The following is a description of a gene set: Mouse Gene Set: LE_EGR2_TARGETS_DN from publication Le N, Nagarajan R, Wang JY, Araki T, Schmidt RE, Milbrandt J (PMID 15695336) species: Mus musculus Genes down-regulated in P14 nerves of transgenic mice having hypomorhic (reduced function) allele of EGR2. Egr2 is a transcription factor required for peripheral nerve myelination in rodents, and mutations in Egr2 are associated with congenital hypomyelinating neuropathy (CHN) in humans. To further study its role in myelination, we generated mice harboring a hypomorphic Egr2 allele (Egr2Lo) that survive for up to 3 weeks postnatally, a period of active myelination in rodents. These Egr2Lo/Lo mice provided the opportunity to study the molecular effects of Egr2 deficiency on Schwann cell biology, an analysis that was not possible previously, because of the perinatal lethality of Egr2-null mice. Egr2Lo/Lo mice phenocopy CHN, as evidenced by the severe hypomyelination and increased numbers of proliferating Schwann cells of the peripheral nerves. Comparison of sciatic nerve gene expression profiles during development and after crush injury with those of Egr2Lo/Lo Schwann cells revealed that they are developmentally arrested, with down-regulation of myelination-related genes and up-regulation of genes associated with immature and promyelinating Schwann cells. One of the abnormally elevated genes in Egr2Lo/Lo Schwann cells, Sox2, encodes a transcription factor that is crucial for maintenance of neural stem cell pluripotency. Wild-type Schwann cells infected with Sox2 adenovirus or lentivirus inhibited expression of myelination-associated genes (e.g., myelin protein zero; Mpz), and failed to myelinate axons in vitro, but had an enhanced proliferative response to beta-neuregulin. The characterization of a mouse model of CHN has provided insight into Schwann cell differentiation and allowed the identification of Sox2 as a negative regulator of myelination., and this is the list of marker genes: Tmem30a, Msmo1, Ogn, Itpkb, Fads1, Nacc2, Mal, Scd1, Rap1gds1, Pmp22, Rtn1, Fth1, Myo1b, Cdkn1a, Me1, Il16, Sncg, Sema6c, Gjb1, Fgf7, Hmgcs1, Lpl, Tmem40, Hmgcr, Nr4a2, Sema3b, Slc25a1, Emp2, Fut8, Scn7a, Fdps, Tiparp, Efhd1, Tgfa, Faah, Gnai1, Cers2, Car3, Mbp, Kcnk1, Pcmt1, Cmtm6, Adipoq, Utrn, Abcb1a, Pim3, Fgl2, Adam10, Ugt8a, Sirt2, Cldn5, Lox, Cyp51, Zbtb16, Errfi1, Pck1, Osbpl5, Mast2, Cpeb2, Cd9, Mpz, Prx, Ephb6, Slc1a5, Ak3, Tkt, Chst2, Ptgds, Myh11, Idi1, Nsdhl, S100a1, Limch1, Myo1d, Nrbp2, Slc6a15, Rnf13, Snca, Pik3r1, Cd55, Cox8b, Mgst3, Pea15a, Pcyt2, Mpdz, Glod4, Lss, Cat, Abca2, Slco3a1, Mapk8ip1 (mitogen-activated protein kinase 8 interacting protein 1), Elovl6, Serpind1, Fgf1, Gfra1, Mt3, Mvd, Fdft1, Cltb, Sult1a1, Tlcd4, Thrsp, Ndrg1, Rgcc, Mt2, Slc2a1, S100b